Given this list of marker genes ZC3H3, ENDOG, CNTNAP2, SIGLEC15, ZC3H13, INE1, NMNAT2, GPRC5A, AKT2, RUNDC3A, H2BC5, SRD5A1, POLD4, CLDN8, GPA33 (NCBI Gene Id 105371599), NBPF14, DNAH3, ATXN8OS, PDIA5, FARP1, ABCC1, AKAP5, ARHGDIB, TMEM8B, GSK3A, SERINC5, MICAL2, CD3E, G6PC3, EPN2, SMIM27, TMPRSS2, BNC2, PINK1, CYP4F12, SOCS7, SLC37A4, CLCN3, ACSM3, PREP (NCBI Gene Id 56239), MCCC2, AHCY, SIL1, ZNF350, DDC, CD5, UBE4B, TSKU, ELMO2, FXR2, PISD, TRAPPC14 (trafficking protein particle complex subunit 14), PRKAR2B, RAB3A, RND1, TMC5, GGTLC1, MAFG, STK3, SLC50A1, ECHDC2, AHNAK (NCBI Gene Id 79026), CACNG4, GGT1, SLC19A2, CAPZB, TMEM33, CALR, SCD, MICALL2, FAR2 (NCBI Gene Id 55711), NDRG1, IL19, HOXC5, ZNF552, ARHGAP26, SYNGR1, GNB5, PIP (prolactin induced protein), CAMP, GADD45B, CA5B, AFF1, HSPH1, MINDY3, HSPA4, GM2A, PYGB, POP1, PDK2, ACACA (NCBI Gene Id 31), PLEKHA1, LGALS3, MAFB, TRIM52-AS1, PIP5K1A, SERHL, IL1B, HOXA10, DZIP1, CHRNA3, FLNB, ALCAM, AQP3, BTG2-DT, ZNF550, TPD52, IFNA1, CYP4F8, RRBP1, CROT, TRIB1, ALDH4A1, ZBTB16, ELOA-AS1, FUT6, ARRB1, SEC14L2, WWC1, FUT3, WWC3, DALRD3, GAL3ST4, NEDD4L, MVK, PEA15, GBA1LP, FKBP5, CSPG5, ENDOD1, LCT, FAM174B, LAMA4, THRAP3, GTF2H3, PTMAP4, ADAM20, GSTM3, MAPT, C1orf116, MYBPC1 (myosin binding protein C1), HSD11B2, FASN, NSG1, DAXX, GFUS, IQGAP2, UGT2B11, EAF2, TTC12, RPL35P8, SORD, RASAL1, AZGP1, NBL1, MZB1, MTMR9, DDX31, KDM4B, DNASE2B, ZNF432, SNTA1, GMDS, H6PD, SLC15A2, S100P, BCAM, AEN, PDXK, COBL, EPHB1, BBOF1, JRKL, AKAP6, ACAA1, FKBP11, GPS1, FMO5, BMP7, LUZP4, RNF125, ST6GAL1, SERHL2, here is a description of the gene set: Little is known of the underlying biology of estrogen receptor-negative, progesterone receptor-negative (ER(-)/PR(-)) breast cancer (BC), and few targeted therapies are available. Clinical heterogeneity of ER(-)/PR(-) tumors suggests that molecular subsets exist. We performed genome-wide expression analysis of 99 primary BC samples and eight BC cell lines in an effort to reveal distinct subsets, provide insight into their biology and potentially identify new therapeutic targets. We identified a subset of ER(-)/PR(-) tumors with paradoxical expression of genes known to be either direct targets of ER, responsive to estrogen, or typically expressed in ER(+) BC. Differentially expressed genes included SPDEF, FOXA1, XBP1, CYB5, TFF3, NAT1, APOD, ALCAM and AR (P<0.001). A classification model based on the expression signature of this tumor class identified molecularly similar BCs in an independent human BC data set and among BC cell lines (MDA-MB-453). This cell line demonstrated a proliferative response to androgen in an androgen receptor-dependent and ER-independent manner. In addition, the androgen-induced transcriptional program of MDA-MB-453 significantly overlapped the molecular signature of the unique ER(-)/PR(-) subclass of human tumors. This subset of BCs, characterized by a hormonally regulated transcriptional program and response to androgen, suggests the potential for therapeutic strategies targeting the androgen signaling pathway. studied in species Homo sapiens Genes up-regulated in MDA-MB-453 cells (class A ER(-) breast cancer) after exposure to the androgen R1881. Human Gene Set: DOANE_RESPONSE_TO_ANDROGEN_UP from publication Doane AS, Danso M, Lal P, Donaton M, Zhang L, Hudis C, Gerald WL (PMID 16491124)